The following is a description of a gene set: studied in species Homo sapiens Human Gene Set: MIR2114_3P from publication Chen Y, Wang X (PMID 31504780) Genes predicted to be targets of miRBase v22 microRNA hsa-miR-2114-3p in miRDB v6.0 with MirTarget v4 prediction scores > 80 (high confidence targets)., and this is the list of marker genes: PRR3, LIMCH1, MEAF6, ERCC1, KPNA6, CSMD1, ARL11, BCAS1, SIGLEC1, AGFG1, LBH, APH1A, RHO (NCBI Gene Id 6010), AGTR2, LARP1B, DPP10, GRIN3A, CHRNE, CTBS, NLK, TMEM167B, LILRA2, RTN4RL1, DHX58, BIRC6, ELOA, PSMC3IP, SENP2 (SUMO specific peptidase 2), MTMR3, TOP3A, C20orf203, MEF2C, STK4, SMPD3, RHBDL3, RHCG, HIF3A, TSPAN3, RAB3B, TBR1, DCP2, VAMP1